Given this list of marker genes SKP2, MIRLET7B, RBX1, MIR98 (NCBI Gene Id 407054), SKP1, UBA52, MIR196A1, MAFK, FBXL17, UBC, CUL1, MIRLET7C, MIR155, RPS27A (ribosomal protein S27a), BACH1, UBB, here is a description of the gene set: species: Homo sapiens The transcription factor BTB and CNC homology 1 (BACH1) is widely expressed in most mammalian tissues and functions primarily as a transcriptional suppressor by heterodimerizing with small Maf proteins and binding to Maf recognition elements in the promoters of targeted genes. It has a key regulatory role in the production of reactive oxygen species (ROS), cell cycle, heme homeostasis, hematopoiesis, and immunity and has been shown to suppress ischemic angiogenesis and promote breast cancer metastasis. part of: KEAP1-NFE2L2 pathway Reactome Pathway: Regulation of BACH1 activity